The following is a description of a gene set: Human Gene Set: GOBP_MAINTENANCE_OF_PROTEIN_LOCATION_IN_EXTRACELLULAR_REGION Any process in which a protein is maintained in a specific location within the extracellular region and is prevented from moving elsewhere. studied in species Homo sapiens, and this is the list of marker genes: LTBP1, FBN1, MICOS10-NBL1, NBL1 (NBL1, DAN family BMP antagonist), NRROS, CER1, DAND5, FBN2